Given this list of marker genes PLIN3, PCBP2, KCTD9, ERP44, RAP2B, TMEM131L, TBC1D3C, SAMHD1, SUPT7L (NCBI Gene Id 9913), TERF2, GCOM1, DECR1, KIDINS220, POLR2M, RAD50, TCF3, WDR74, TNXB, FEN1, GM2A, NUP50, ZNF32 (zinc finger protein 32), PSMB1, R3HDM1 (R3H domain containing 1), NADK, HHEX, PGAP3, APOBEC3G, ICMT, TASOR (NCBI Gene Id 51687), MAML1, WASHC2A, PAICS, FABP5, UBE2B, RASA4B (RAS p21 protein activator 4B), PRP4K, WAPL, IMP4, TBC1D10B, YWHAQ, AHR, PPFIBP1, RRM2, HRK, ARMC8, IKZF1, ATF7IP2, RASA4, ELMO2, CPT1B, CNIH1, ANXA2, AIMP2, AMPD3, TIGAR, TM9SF2 (transmembrane 9 superfamily member 2), TTI1, YLPM1, ARF3, CHKB-CPT1B, OTUB1, DCAF1, GTF2H5, COA3, SPTSSA, TXLNA, AAMDC, PLN, QKI, GABBR1, IPO5, ETFDH, SLAMF7, COX6A1, SYNJ2, ZNF207, SLC7A7, CDC14A, MAST2, HDAC2, ERAP1, LRRFIP2, CIAO1, CD36, TBC1D3F, ORC5, GALNT10, PTPN2, ATF6B, CHST11, ATP6V1C1, TBC1D3H, DHX16, MNDA, ITGA4, DET1, SNAPC5, CNTNAP2, GK, CYB5R3, FUCA1, NFYA, PLXNC1, MT1X, GLYR1, GPD1L, AASDHPPT, PRDX2, RNF11, IL6R, FBXO38, DNM1L, PPP4C, CSNK2A1, SNRNP27, GLRX, TOP1, NDC80 (NCBI Gene Id 10403), NCOA4, CCNB1IP1, ITCH, WNK1, RNF19B, RARA, GPX1, NDUFC1, DNAJC10, SGCB, ZNF236, UTP14A, STN1, COPS8, CDK2AP2, TMEM260, C1QBP, DYNLT3, SHC1, BAX, WASHC2C, MTHFR, KRT86, C10orf88, BLMH, IGHG1, PAK1IP1, RABEP2, GYG1, SPIN1, PPP1R7, RANBP9, LIMS1, TBK1, ARF4, TAF9B, PDIA6, UBR5, SNRPC, PAK1, RAP2A, FBXO22, MYO9B, TBC1D9B, PHKB, MT2A, IGHV1-69, IGHG3, NUCB2, PMVK (NCBI Gene Id 10654), ANKMY1, ISG15, ARFIP2, ZNF117, CALM3, DENND4A, KDELR1, GSTM4, PTPN9, MBNL2, MDC1, PPP2CA, RPS6KC1, ERCC1, FTSJ1, CPNE3, PCMT1, DESI2 (NCBI Gene Id 51029), SIGLEC6, MIR22HG, ZNF226, RELA, PAIP1, ASPH, PSMA6, IGHV4-31, NFYB, CRELD2, ZNF780A, IL21R, UQCRQ, SNRNP200, GPM6B, ZCCHC8, TYMP, XBP1, GOLGB1, BCL2L1, TERF1, RCN2, TOR1A, MED8, SAP30L-AS1, NAB1, OTUD4, TIMM17A, RPN2, CYFIP2, IGHD, RNASE6, EIF2S1, PRKAG2, UBXN2B, SLC20A1, STK38L, TBC1D3, SNAP29, BLOC1S1, CLTB, NEMP1, DCTN2, RPRD1A (NCBI Gene Id 55197), ZNF451 (NCBI Gene Id 80822), EIF4E, KIN (NCBI Gene Id 22944), OGFOD1, CD247, COPS6, IGHM, PELI2, CELSR1, AIMP1, IGHV3-23, ZNF83, SEC31A, NET1, CCNG1, ATP5MG, DYNLT1, NPRL2, GNB1, BLVRB, MAK16, HEG1, NANS, LYRM9, CLCN3, BAZ1A, PBX2 (PBX homeobox 2), LTN1, DMAC2, PASK, SOD2, IDI2-AS1, CTRL, MICAL3, CYLD, TPD52L2, CBX5, NUP58, LARP4B, PDE5A, IFIT1 (interferon induced protein with tetratricopeptide repeats 1), IGHG2, TM7SF3, UBE2J1, YARS1, SPATA1, COPB2, CDC16, MCCC2, ZNF780B, PYROXD1, BAZ2B, IGHA1, WSB2, BTN2A2, BBX, TENT5A, THSD1, ITFG1, U2AF2, DDX60, ATP6AP2, HECTD3, TMCO1, AGPS, KLHDC10, SLC39A9, ANXA6, RIOK3, ANKFY1, DGUOK, PRKCD, THOC7 (THO complex subunit 7), FLOT1, EPHA4 (EPH receptor A4), USP4, MED1, ITGAL, RAB5IF, TMCO6, M6PR, MILR1, VPS33B, MED6, ATP1A1, FUBP3, TTF1, TOR1B, AP5Z1, SEC31B, SF3B3, SYNCRIP, ST13, GTPBP8, GART, ME2, SERPINB1 (serpin family B member 1), MYO5A, PEX7, RRS1, SMAD2, PFDN4, FAHD2A, PEX5, ANXA4, PLEKHJ1, RHEB, SAPCD1 (suppressor APC domain containing 1), DNAJB12, PHF20, PIP4K2B, POLE3, IPO9, TOP3A, UTP14C, SLC35D1, TALDO1, RNF113A, COPS5, CEBPG (CCAAT enhancer binding protein gamma, NCBI Gene Id 1054), FGR, IGHA2, CCNG2, BECN1, PDIA4, CD58, RPF1, PSMD14, MAP3K8 (NCBI Gene Id 8040), RBM19, DCAF8, PSEN1, GTF2A2, SLFN12, RANBP2, EIF4E2, here is a description of the gene set: Genes up-regulated in B cell 7d vs 0d in young adults (18-50) after exposure to Fluarix/Fluvirin, time point 7D Here we have used a systems biology approach to study innate and adaptive responses to vaccination against influenza in humans during three consecutive influenza seasons. We studied healthy adults vaccinated with trivalent inactivated influenza vaccine (TIV) or live attenuated influenza vaccine (LAIV). TIV induced higher antibody titers and more plasmablasts than LAIV did. In subjects vaccinated with TIV, early molecular signatures correlated with and could be used to accurately predict later antibody titers in two independent trials. Notably, expression of the kinase CaMKIV at day 3 was inversely correlated with later antibody titers. Vaccination of CaMKIV-deficient mice with TIV induced enhanced antigen-specific antibody titers, which demonstrated an unappreciated role for CaMKIV in the regulation of antibody responses. Thus, systems approaches can be used to predict immunogenicity and provide new mechanistic insights about vaccines. from publication Nakaya HI, Wrammert J, Lee EK, Racioppi L, Marie-Kunze S, Haining WN, Means AR, Kasturi SP, Khan N, Li GM, McCausland M, Kanchan V, Kokko KE, Li S, Elbein R, Mehta AK, Aderem A, Subbarao K, Ahmed R, Pulendran B (PMID 21743478) Human Gene Set: NAKAYA_B_CELL_FLUARIX_FLUVIRIN_AGE_18_50YO_7DY_UP studied in species Homo sapiens